The following is a description of a gene set: Human Gene Set: GOBP_REGULATION_OF_ACTIN_FILAMENT_BASED_PROCESS Any process that modulates the frequency, rate or extent of any cellular process that depends upon or alters the actin cytoskeleton. studied in species Homo sapiens, and this is the list of marker genes: ABI2, MKKS, ADD1, SIGLEC15 (NCBI Gene Id 284266), WASHC3, WAS, PRKN, RGS4, BRK1, MIR138-1, SYNPO, PLEKHH2, ADD2, PPM1F, ADCY10, NCKAP1L, CDC42EP2, ODAM (NCBI Gene Id 54959), DSTN, PRKCD, INPPL1, TMSB4Y, CARMIL1 (NCBI Gene Id 55604), CAPZA3, RHOF, STAU2, ARHGEF15, EPHA1, WDR1, ARFIP1, ARAP2, MTOR, KCNJ2, TMSB4X, JAM3, SVIL, LMOD3, CRACD, PRKD1, RAPGEF3, WASHC2A, PAK3, MLST8, CORO1B, DSP, TENM1, CAPN10, ARHGAP6, DNAI3, ARHGEF10 (NCBI Gene Id 9639), PHLDB2, WASF1, TMOD1, TWF1, MAGEL2, SLC4A2, RICTOR, ARHGAP44, BIN1, RDX, SPTBN2, TTC8, ARHGEF16, MYLK2, RHOC, EPS8, TGFBR1, CDK10, MYH7B (myosin heavy chain 7B), CAPZA2, FGF13, PREX1, RHOD, TRIOBP, CAMK2D, SRI (sorcin), PIK3R1, EPHA3, BAIAP2L2, CORO1A, ATP2A2, FHOD1, F2RL1, C15orf62, STMN1 (stathmin 1), ABRACL, CYRIB, ABL2, PAK2, PICK1, CCDC88A, BBS4, CDC42EP5, ACTN2, ALMS1, INPP5K, PLEK, ARHGEF5, MIR149, WASHC5, TJP1, FCHSD1, CNN2, ABITRAM, EVL, CAV1, MYO3B, SFRP1, PROX1, C9orf72, ARHGAP35, RHPN2P1, PDPN (NCBI Gene Id 29912), ECT2, SHANK1, MYOC, ARHGAP18, CORO2B, KIRREL1, CLASP1, EDN1, RHOA, MYLK3, BST1, CDC42EP3, DVL2, PDGFRA, TACSTD2, BAIAP2, VIL1, IQGAP2 (IQ motif containing GTPase activating protein 2), WASHC4, ASAP3, APOA1, PDGFA, COTL1, ACTG1, SCIN, GMFB, NCK1, PKP2, RHPN1, NRP1, SPTBN4, TSC1, SNX9, CACNA1C, JUP, RANGRF, CXCL12, TNNC1, DVL3, LPAR1, EZR, CARMIL3, FRMD7, GBA2, SDC4, WASH3P, KANK1, ARPC2, FLNA, FLII, RAC2, PFN3, BAG4, ARF6, ARAP3, SMAD4, DSC2, ABL1, EFNA5, DLC1, CSRP3, ARHGAP28, CAV3, NAA20, SPTBN1, HIP1R, RYR2, ESAM, TMEFF2, SLC9A1, ARHGAP17, CX3CL1, CFL2 (cofilin 2), DAPK3, AVIL, MTPN, ROCK1, MIR214, PDXP, ADD3, TAOK1, F11R, HCLS1, FCHSD2, TGFB2, S100A10 (NCBI Gene Id 6281), GJA5, CCL26, TGFB3, CAPZB, MIR21, CTNNA2, SH3BP1, FRMD6, CYRIA, CTNNA3, HCK, PEAK3, SPTAN1, CFL1, PXN, ACTA2, DSG2, CDC42, DLG1, RAC3, STRIT1, RHOBTB2, AMOT, PDE4D, RHPN2, SMAD3, RND3, PFN1, MTSS1, WASF3, LMOD1, SLIT2, EPHA5, WASHC1, ARPC5, TWF2 (NCBI Gene Id 11344), LMOD2, DIXDC1, NPHS1, S1PR1, SWAP70, TPM1, NF2, SPECC1L, TAOK2, WASF2, LATS1, CCL24, NEDD9, TESK1, ARFIP2, AKAP9, NCKAP1, MIR20A, NCK2, MIR448, KANK4, SUMO1, RHOQ, PIK3R2, TACR1, SERPINF2, FZD10, PDGFRB (platelet derived growth factor receptor beta), CD47, GMFG, ITGB1BP1, SMIM22, RHOG, CCN2, WASHC2C, NEB, PLEKHG2, TGFB1, MYBPC3, TMOD2, PTGER4, PPM1E, LIMCH1, NAA80, PFN2, ROCK2, SSH3 (slingshot protein phosphatase 3), CYFIP1, HAX1, TAC1, CCL21, ATP2A1, TRIM27, CAPZA1, CIT, CGNL1, ANKRD23, TRPM2, HRAS, RAC1, FSCN1, SPTB, MET, MIR335, ARPIN, ELN, GATA4, TMOD4, CDC42EP1, PIK3CA, SHANK3, WNT4, PDE4B, ASB2, SPTA1, RGCC, CRK, BRAF, HCN4, BMP10, SSH2, ARF1, ARHGEF19, VANGL2, BST2, ANK2, VILL, DMTN, CARMIL2, MYADM, TRPM4, LRP1, GRB2, RALA, RND2, BCAS3, ARHGEF26 (NCBI Gene Id 26084), FAM107A, AP1AR, CCL11, CDC42EP4, VASP, XIRP2, OR2A4, GRHL3, FER, CDK5R1, TMOD3, GPR65, PYCARD, CCR7, CELSR1, OAZ3, RNH1, LIMK1, GPM6B, SYNPO2L, ARHGAP40, PRKCE, MIR1-1, RASA1, CLASP2, ARAP1, BAIAP2L1, ARHGEF18, STC1, SEMA5A (semaphorin 5A), CTTN (NCBI Gene Id 2017), ARFGEF1, HRG, CD2AP, AKAP13, ADORA1, PLN (NCBI Gene Id 5350), CSF1R (colony stimulating factor 1 receptor), MYO3A, PPFIA1, PTK2B, ARPC3, LIMA1, CYFIP2, CAPG, SYNPO2, FERMT2, KANK3, MYH9, SORBS3, NGEF, SSH1, KANK2, SCN5A, GSN, ATP1A2, ARHGEF10L, RHOBTB1, CSF3 (NCBI Gene Id 170794), WHAMM, PAK1, ALOX15, WASH6P, RND1, ARPC5L, SPTBN5, ZEB2, DAAM2, ITGB3 (integrin subunit beta 3)